The following is a description of a gene set: species: Mus musculus Mouse Gene Set: chr1E1, and this is the list of marker genes: Gm28188, Gm18185, Gm23036, Gm24122, Gm53054, Cntnap5b (NCBI Gene Id 241215), Prdx2-ps1, Gm23602, Gm18728, Gm18700, Gm20268, Gm29667, Psmb6-ps2, Gm22034, Gm18969, Gm23965, Gm19029, Gm20281